The following is a description of a gene set: studied in species Homo sapiens Poor gross motor coordination An abnormality of the ability (skills) to perform a precise movement of large muscles with the intent to perform a specific act. Gross motor skills are required to mediate movements of the arms, legs, and other large body parts. Human Gene Set: HP_POOR_GROSS_MOTOR_COORDINATION, and this is the list of marker genes: FOXP2, DCX, PWAR1, MAGEL2, CAMTA1, SNORD115-1, HERC2, SNORD116-1, KCNQ2, MKRN3, PWRN1, GDAP1 (ganglioside induced differentiation associated protein 1), NPAP1, FKRP, PDHX, POMT1, LARGE1, GMPPB, POMT2